The following is a description of a gene set: species: Homo sapiens Human Gene Set: GOBP_NUCLEOTIDE_EXCISION_REPAIR_DNA_GAP_FILLING Repair of the gap in the DNA helix by DNA polymerase and DNA ligase after the portion of the strand containing the lesion has been removed by pyrimidine-dimer repair enzymes., and this is the list of marker genes: POLK, POLD1, POLB, POLD3, POLE, LIG4